Given this list of marker genes OVOL2, MCU, MSX1, ZNF207, STK10, GRAP, SLC35C1, CCL28, NR2F6, CIAO2A, SH2D1B, IGF2R, GCNT2, NABP2, KRCC1, MIR137HG, NSMCE2, RUNX3, SARNP, STX16, PCDH7, ZMAT4, MMRN1, COLQ, SMIM19, KMT2A, CALCOCO1, TREML2, TLCD5, CD96, RIN2, GRIA1, ZNF572 (NCBI Gene Id 137209), SERPINI2, RBFOX2, POU3F4, STARD13, CRADD, PDE6C, APOLD1, ESPNL, FAM78A, VIP, COLEC11, ARPC2, CNTF (NCBI Gene Id 1270), TMEFF1, HOXA4, OSER1, CREBL2, ALKBH6, KLRC1 (NCBI Gene Id 3821), TMEM164, ECM1, SH3KBP1, DEF6, AGT, SRGN, AP1G2, CHN2, RIMS2, PLA2G4F, LAYN, CDC37, ZFP91, ACKR1, CDK12, RINL, IGFBP4, KCNQ1DN, ELAVL4, TMEM204, KALRN (NCBI Gene Id 8997), TFE3, RNF40, VPS39, SLC30A7, SNX21, COL6A3, PCDHGB2, ST13, CMTM8, ZBTB33, KDF1, MCTS1, WHRN, ETNK1, RIPOR1, RNF122, RHOBTB1, AMFR, NASP, TRIB1, TTPAL, CLIC1, MRPL24, MIA, AIG1, PIH1D1, CUEDC1, CLVS1, ROBO1, SPI1, GPC4, NEDD8, ACTN1, FAM110A, PDAP1, ADGRG3, ARHGAP20, STAT5B, FBLIM1, PLEKHS1 (NCBI Gene Id 79949), RAB10, HSD3B7, ERG, ZNF282, MUSK, ANGPT2, CEP83, IL24, CTSW, ZC3H11A, PEG10, ELK3, CNN2, S1PR2, CNOT1, FHL1, XPO5, FILIP1, USHBP1, MED14, LAT, HSD11B1, ACTB, DES, PTGIR, BEND4, PSME2 (proteasome activator subunit 2), NRP1, GMPR2, ARHGAP12, LCK (NCBI Gene Id 95387), DAB2IP, DHX15, STX19, PTTG2, CCDC51, PLCG1, MS4A1, CCDC91, PNMA1, ADAMTS7, CD6, CREB3 (cAMP responsive element binding protein 3), WIPF1, CITED2, DGKZ, STRBP, GIT1, RLIM, ITPR2, PAX4, TMEM132E, PTPN11, MADD, SORBS2, KANSL1, PYM1, PIK3CG, PTK7, DALRD3, VAMP8, PLEKHH2, RBPJ, ATP8B2, TMIGD1, FZD6, L3MBTL2, PHACTR3, WNT3, CTSK, GALNT2, NR1D1, POF1B, NEURL2, ATOH8, SDCCAG8, UBE2E3, MMP9, LINC01138, RASGRP3, MLLT10, ZDHHC5, MIR22HG (NCBI Gene Id 84981), POLR1D, BLNK, B3GNT7, HOXC4, MED26, ZNF593, CD180, MYLIP, ARF6, IMP3, LDLRAP1, RPL11, PDE4D, ACSL5, PPIF, FBXL5, CYFIP1, EGR1, NCF4, LDB2, TIMP4, INHA, RORA, RAMP2, HNRNPK, GTF2B, ZMYND8, MEIS2, C1QTNF6, CAB39, CNTN4, DROSHA, EIF5A, KIAA0040, NHERF1, BABAM2, CRK, TMA7, ZNF296, SOX30, DNASE2B, TCP11L2, RWDD4, BCL2L2, CSRNP1, ATXN1, ELP5, CIB1, DOK1, C6orf89, ADRB3, SOX14, RASA2, CD5, ALS2CL, ZHX3, ARSG, ORMDL2, OSBPL3, CASP8, NR4A3, ARHGEF15, MIDEAS, BIN1, TRPC6, CHI3L1 (chitinase 3 like 1), SELE, ENPP1 (ectonucleotide pyrophosphatase/phosphodiesterase 1), ZBTB8OS, KCNN4, HIVEP2, MYO10, CYB561D2, LIN7C, IL17RE, SEMA4C, SNX20, MAP4K4, MMP3, ITGAL, RAP2C, MAPK14, ZNF800, GTSF1, NPR2, UBTF, CNTLN, DIXDC1, CAPZA1, ETS1, RASSF1, OTP (orthopedia homeobox), FAM241B, GAPT, FGR, TIAL1, EGR3, SS18, PDLIM2, EGFL7, SH2D2A, TBC1D17, PRICKLE4, SLPI, IL36A, FCHO1, HRH4, PRF1, DOCK8-AS1, LYL1, TNFSF13, UBE2B, CNPY2, CTSS, LIME1, IGF2BP1, CFAP53, MYO1C, CD40LG, GJB6, FOXO4, MAPKAPK2, SLC2A9, POLH, LIMD2 (LIM domain containing 2), MTCL2, RBBP7, ID3, SLC38A6, MARK1, BCL3, POLD4, FOXN3, ZMAT3, HHEX, PCDH1, PPP2R5C, UBE2L3, FSTL1, DAPP1, RASAL1 (RAS protein activator like 1), B4GALNT1, SEMA6C, TSKU, HOXB6, PDCD10, LAG3, MIR17HG, ZNF706, SERPINI1, CMKLR1, PPP1R12A, QPCT, FGFR4, CD86, LINC01565, NDUFS2, ARAP1, TAB2, GNG11, SH3BP4, CX3CR1, LTBR, NPRL2, SESTD1, CRMP1, LRRC15, STX5 (syntaxin 5), NEDD9, KLRC4, LHX2, GCNT3, DHX8, OMA1, ZC3H10, SKAP2, AK8, RHOD, PUS7L, FOSL1, XCL2, NCK1, CITED4, EPC2, PITPNC1, CPNE8, TSEN54, IRAK4, WDR81, DTX3, PDGFD, EMC3, FBRS, MLLT11, PRDM12, STRN, CD79A, CHIC2, CAST, EPHA2, HMG20B, RAB11B, KCNJ1, CALN1, FCGR2C, NFATC2, ADAM15, PRKCH, CTSA, C5orf22, UCKL1 (uridine-cytidine kinase 1 like 1), ZEB2, MGAT4A, VWA5A, GPX1, CDK5, CKMT1B, RPS20, NPAS2, FHIP1B, NR4A2, TRAPPC11, CKS1B, S100A9, SEPTIN1, MFAP2, DCTN2, TMEM40, DNAJA2, SSH1, ACAP1, FCGBP (Fc gamma binding protein), NDUFA4, PIK3R4, ZNF687, SLC1A5, GK, TMEM184A, SMAD3, PUM1, C22orf15, TRIP10, TRIM25, TGM3, SH3BGRL, SMG1, OTUB2, ELOVL1, GPR132, GRB7, VLDLR, CARF, TOM1L1, HOXD1, HCAR2, PATL1, TMIE, ST7L, HCST, RHOH, CMAS, CTDNEP1, ADGRF1, DNAJC14, ARHGAP4, CD248, CNNM4, KLRC3, SNF8, NOS1, PPP1R16B, ZNF143, TNKS2, LRRC1, GORASP2 (golgi reassembly stacking protein 2), RBKS, PLEC, RBBP4, AP2B1, GFI1, TREX2, VAMP5, SOSTDC1, TRAT1 (NCBI Gene Id 51488), CD247, SASH3 (NCBI Gene Id 93952), NLK, TUSC3, FERMT3, TSC22D2, PRDM1, RGS3 (regulator of G protein signaling 3), DNM2 (NCBI Gene Id 338330), MAP7D1, ARHGDIB (Rho GDP dissociation inhibitor beta), PRR5L, MARK4, CLEC14A, ERF, MSL3, PTPRC, PIK3R1, NOTCH4, GPR183, SH3BP1, RASD2, DNMT1, ATP5PD, CYP2B6, ARHGEF4, SHISA5, TOMM5, CCNJL, SIPA1, HOXA11, ETS2-AS1, CBLB, CPA2, PTPN6, GNL2, SRR (NCBI Gene Id 63826), KLHL3, CD40 (NCBI Gene Id 958), JAML, SH2D3A, GPR18, KIZ, CASKIN2, DCX, RPS6KA4, TGFBR2, OR51E2, NEDD4, PTPRN, IL23A, WNT7A (Wnt family member 7A), LIMK2, DQX1, PER1, NXPH1, ADAMTSL1, PPP1R9B, ADAM10, RTKN, MYO18A, PAFAH1B1, ARRB2, PAK3, SMG6, SGCD, NIPAL2, PDZRN4, GDNF, ATXN7L1, ZNF768, TREML1, IFT43, EPS8L2, PRRT2, GAB2, VAV1, DRP2, LIF, PRKAG2, CLCN3, NCALD, ZBTB7B, TGFB3, SH3BP5L, SLC25A28, RPL23, NFKBIE, PLEKHA1, FEM1C, SLC4A1AP, GGNBP2 (NCBI Gene Id 84160), MPL, SLC43A1, SLC20A2, BUB1B, M6PR, PHEX, FOXP1, CD19, KMT2D, TLL2, PRKACA (protein kinase cAMP-activated catalytic subunit alpha), EVL, ADAMTS4, TMEM69, ROBO4, ARF4, LOXL3, DLX5 (distal-less homeobox 5), MBNL1, MAP3K11, RAB39A, FAM106A, RASA3, BDNF, SMAD5, MID1, PICALM, SMCR5, PURA, PARP8 (NCBI Gene Id 79668), DHPS, E2F3, CHD2 (NCBI Gene Id 283680), RNF31, FLT3LG, METTL2B, TNFRSF6B, SP3, DPPA4, ABCC10, VPS25, ABCA2, DGKH, KCNQ5, FTH1, CLDN5, TBL1XR1, SLAMF1, LIX1L, PRRG3, CDYL, HBEGF, PTPRCAP, EXTL3, TMEM161B, MLLT6, CXADR, ARHGAP45, BCL6, YWHAH, LPCAT4, CD4, DCK, SPIB, RSF1, RIN1, METTL2A, CCDC9B, LSR, GNB1L, FEV, IQUB, ZNF12, FLNB, SEC24C, C2CD2L, EGFLAM, HTR2C, ZNF276 (NCBI Gene Id 92822), ALOX12B, LINC02908, SP6, ADAMTSL3, RAC1, RBMS2, NOSTRIN, AMD1, C6orf47, KLRC2, SRPRA, NFKBID, CXCR3, CD200R1, PRKACB, PTPN7, EXTL2, FIBP, KRIT1, TRAF3, ALDH3A1, HMGA1, DUSP4, ABL1, ALDH16A1, CA4, FUT10, WWP2, NOVA2, CRTC2, GPR65, HDDC3, MARCO, SEPTIN9, NUFIP2, DLC1, ADCY4, PIK3CD, S1PR4, XPNPEP3, ABR (NCBI Gene Id 82701), CMTM6, AFF1, BMP7 (bone morphogenetic protein 7), OLIG3, SPARC, LNX2, CALCRL, SLC4A2, BMP10, HCLS1, MSANTD2, ADAMTS3 (ADAM metallopeptidase with thrombospondin type 1 motif 3), CCDC85B, IKBKB, FOXRED1, OFCC1, TFEC, ARPC5L, ARFGEF2, GPD1, ZCCHC7, MCC (NCBI Gene Id 4163), AQP3, ACTR2, PGM1, MOAP1, ENPP2, PCBP4, LTC4S (leukotriene C4 synthase), TLN1, VCL, PRICKLE2, SLC30A4, SLC13A5, AAMDC, DGKA, LMX1B, NRK, CEBPE, FAM170A, TIMM44, PELO, ORAI2, WAS, SOWAHA, VGF, RILP, SEMA3F, COX17, MEF2C, MOSPD1, FCER1G, NKX2-1, IPO7, TNFSF13B, EPHX4, LINC00656, CNKSR1, FLT1, GPR87, ACY3, STX11, RPS6KA3, BUD31, EPN3, CALR, PTH1R, FBXL14, RTL10, NDRG4, BMP2, MYCT1, AGPAT1, ARHGEF2, AQP5, JPH3, GRK5, SESN3 (NCBI Gene Id 143686), GJA5, LSP1, ATP13A2, CLDN12, BPIFB1, CDH5, DCTN3, PTEN, NCF2, CREM, FOXO3, RNF138, ZNF205, EFHB, HAPLN1, UBXN10, MIRLET7BHG, EPB41L1, RNF152 (ring finger protein 152), KCNA2, NUP210L, EXOSC9, NTF4, CD93 (CD93 molecule), NFKB1, ESRRA, BTK, HOXA10, CANX, PIP4K2A, TPP2, MEFV (MEFV innate immunity regulator, pyrin), TMOD3, NHSL2 (NHS like 2), KDELR3, TLL1, SLC16A13, ATP2B4, TGIF1, BMX, CD2AP (NCBI Gene Id 25916), LCP1, ETF1, GGN, TM9SF3, LLGL2, CMIP, HCAR3, CSF2, TXNDC17, ZBTB18, PROP1, PITX2, TNFSF4, TYROBP (NCBI Gene Id 7305), ARHGAP15, AGBL5, NKAPD1, ATP2A3, ARMCX4, ZNRF2, LMO4, MYRFL, NUDT21, KLRG1, CNRIP1, USP3, DKK2, CD101, TGIF2, RUNDC3A (NCBI Gene Id 10900), TIMP1, NDUFAF3, MYH10, STIM1, LHFPL1, C20orf204, PLA1A, FPGS, HM13, H3-3A, CCL2, KLF9, TRIM41, ELK4, HYAL2, JUNB, RUVBL1, CLINT1, AGAP2, SSH2, CARD6, SF1, GGT7, KPNB1, CDCP1, HFE, SH3TC1, TREX1, BCL9L, DPP3, LMO3, CYB561, PDGFRB, ARL4C, QSER1, RARA, TMEM59L, CYSLTR1, ATL3, LRP5, ITGB1, SPEG, CCDC80, SPTAN1, GAREM1, DDIT4, ITGA1, LZTS2, SERINC2, CHMP1B, TRMT2B, DLL3, CRYGB, TCF12, SP7, PPARGC1B, ZNF668, FBXW11, LTB, RNF128, RHEBL1, PIH1D2, SPNS3, IL7R, GRB10, BRAF, BIN3, CAVIN2, TCF15, SHC3, ARL6IP5, XCL1, VASP, CCL20, SHC1, KRT23, PDGFB, BDKRB2, STK4, FRMPD1, SCN3B, CLEC1B, DMTF1 (cyclin D binding myb like transcription factor 1), SCN2A, E2F5, PLA2G2E, YY1AP1, ZNF35, RAB43, SCN8A, MYO1E, CALD1, SOS2, RALB, CCR4, LRFN4, PSTPIP1, NT5C2, FXYD5, KCNAB2, DENND3, CDC42SE1, SGK1, NFIA, RMI1, BORCS6, HCAR1, SLC39A11, STAT4, TEAD3, CRACR2B, SSBP4, ARL8B, DHCR24, C17orf78, SIGIRR, TMEM154, TMEM100, CNNM1, TAF5, TAB3, SLC44A4, ZHX2 (zinc fingers and homeoboxes 2), SNCAIP, DLL4, NKX2-8, TPM2, TNFRSF13B, YIF1A, NAALADL2, GATA3, MGLL, HELZ2, FCGR2B, YARS1, CAP1, IL11RA, SH2B3, SRSF8, SLC17A9, SLC35C2, SCN3A, FAM20A, PRKRIP1, CALM2, CCR1, RALGAPA1P1, CDKN1A, TUBA1B, C6orf136, YTHDC1, TRPC4AP, ADGRA2, LHX1, TAF8, TEAD4, ESAM, ITPR3, MAP4K1, GAD2, TFB1M (NCBI Gene Id 51106), CACNG2, SPACA9, PLCB2, TSC22D4, AKT1S1, IL10, INTS3, ARHGAP30, PLXNA2, CARD9, TRAF3IP3, IL1RN, NKAIN1, IKZF2, KDM6A, EIF3K, TMUB2, GATA4, CLEC7A, RALGDS, IL18RAP, FAM13C, PTPRG, ETV5, SHROOM1, SLC9A9, CCDC88A, TMEM209, WDFY4, LRP2, MAP4K2, NRXN3, CLTC, RAB11A, CD3E, CCDC149, ZNF646, PCIF1, JAK3, RCC2, PHC1, HGF, DZIP1, SNX22 (sorting nexin 22), FURIN, TPM3, TNS2, PSAP (NCBI Gene Id 83009), RAB5IF, TMEM131L, RPL41, VEGFD, KDM5C, GPR150, MICAL2, GOLPH3L, DAP3, APPL2, RCAN2, ZIC4, NFAT5, SEC61A1, FGF23, PKN3, THBS2, MAP2K6, DOCK4, WDR11, SBF2, CTCF, SLC25A5, ACAP3, ZBTB9, TAGLN2, ASH1L, LYN, TRERF1, PDE3A, FGFR2, FRS3 (NCBI Gene Id 10817), SP2, CDK2AP2, RHOV, ITPR1, CLSPN, SKAP1, WWC1, RGS14, GPATCH11, FMNL1, CSF3R (NCBI Gene Id 1441), MPO, ZNF532, RIN3, RHOJ, FKBP9P1, MSN, ZNF410, KLF12, LTBP3, PDGFRA, IL2, ERBIN, GAS7, IGF1, ETV6, RHBDF1, BAZ2A, TMEM71, ODAPH, CLEC10A, SND1, here is a description of the gene set: Human Gene Set: RYTTCCTG_ETS2_B Genes having at least one occurrence of the highly conserved motif M16 RYTTCCTG in the regions spanning 4 kb centered on their transcription starting sites. This matches the ETS2 transcription factor binding site V$ETS2_B (v7.4 TRANSFAC). from publication Xie X, Lu J, Kulbokas EJ, Golub TR, Mootha V, Lindblad-Toh K, Lander ES, Kellis M (PMID 15735639) studied in species Homo sapiens Comprehensive identification of all functional elements encoded in the human genome is a fundamental need in biomedical research. Here, we present a comparative analysis of the human, mouse, rat and dog genomes to create a systematic catalogue of common regulatory motifs in promoters and 3' untranslated regions (3' UTRs). The promoter analysis yields 174 candidate motifs, including most previously known transcription-factor binding sites and 105 new motifs. The 3'-UTR analysis yields 106 motifs likely to be involved in post-transcriptional regulation. Nearly one-half are associated with microRNAs (miRNAs), leading to the discovery of many new miRNA genes and their likely target genes. Our results suggest that previous estimates of the number of human miRNA genes were low, and that miRNAs regulate at least 20% of human genes. The overall results provide a systematic view of gene regulation in the human, which will be refined as additional mammalian genomes become available.